Given this list of marker genes CD36, KIAA1217, CA4, BTNL9, RNF144B, FCN3, SLC6A4, RNASE1, NTRK2, RGCC (NCBI Gene Id 730127), TNFSF10, EDN1, IL7R, DUSP6, here is a description of the gene set: from publication Travaglini KJ, Nabhan AN, Penland L, Sinha R, Gillich A, Sit RV, Chang S, Conley SD, Mori Y, Seita J, Berry GJ, Shrager JB, Metzger RJ, Kuo CS, Neff N, Weissman IL, Quake SR, Krasnow MA (PMID 33208946) species: Homo sapiens Human Gene Set: TRAVAGLINI_LUNG_CAPILLARY_CELL